The following is a description of a gene set: Mouse Gene Set: GOBP_POSITIVE_REGULATION_OF_TOLL_LIKE_RECEPTOR_4_SIGNALING_PATHWAY Any process that activates or increases the frequency, rate, or extent of toll-like receptor 4 signaling pathway. studied in species Mus musculus, and this is the list of marker genes: Nr1h3, Ninj1, Wdfy1, Ltf, Znrf1, Lbp, Tirap, F2rl1, Ifi35, Ticam2, Hmgb1, Cd14, Ptpn22, Peli1